The following is a description of a gene set: Human Gene Set: DARWICHE_PAPILLOMA_PROGRESSION_RISK Genes that classify progression risk of benign papilloma samples: low vs high risk. studied in species Mus musculus from publication Darwiche N, Ryscavage A, Perez-Lorenzo R, Wright L, Bae DS, Hennings H, Yuspa SH, Glick AB (PMID 17525749) Chemical induction of squamous tumors in the mouse skin induces multiple benign papillomas: high-frequency terminally benign low-risk papillomas and low-frequency high-risk papillomas, the putative precursor lesions to squamous cell carcinoma (SCC). We have compared the gene expression profile of twenty different early low- and high-risk papillomas with normal skin and SCC. Unsupervised clustering of 514 differentially expressed genes (P<0.001) showed that 9/10 high-risk papillomas clustered with SCC, while 1/10 clustered with low-risk papillomas, and this correlated with keratin markers of tumor progression. Prediction analysis for microarrays (PAM) identified genes that distinguished the two papilloma classes, and a majority of these had a similar expression pattern in both high-risk papillomas and SCC. Additional classifier algorithms generated a gene list that correctly classified unknown benign tumors as low- or high-risk concordant with promotion protocol and keratin profiling. Reduced expression of immune function genes characterized the high-risk papillomas and SCC. Immunohistochemistry confirmed reduced T-cell number in high-risk papillomas, suggesting that reduced adaptive immunity defines papillomas that progress to SCC. These results demonstrate that murine premalignant lesions can be segregated into subgroups by gene expression patterns that correlate with risk for malignant conversion, and suggest a paradigm for generating diagnostic biomarkers for human premalignant lesions with unknown individual risk for malignant conversion., and this is the list of marker genes: CXCL16, NEK4, GGT7, ABHD14B, LIM2, PRKX, EGLN3, TEX26, RINL, GSTM5, NUDT12, PTX4 (pentraxin 4), MORN5, SGTA, ZNF787, LAG3, R3HCC1L, MXI1, CALCOCO1, C16orf96, XPC, ACKR3, C4orf54, SMIM33, KIF6, MCM4, SERPINH1, STOM, SLC38A10, PSORS1C2, GJB2, LGALS2, XDH, RELN, PRRT1, CD2AP, CYP3A5, TRAF2, HAND1, PLEKHM2, SIGLEC5, TMOD1, ZSCAN2, IGKV1-27, CLYBL, TRBV11-3, NR6A1, TIA1, MFAP3L, HGD, IQCF1 (IQ motif containing F1), TTN, RAMP2, RGS14, CD2, CRKL, GSDMC, GPR37, DYRK1A, CATSPER3, TRPC6, COL20A1, MAN2A2, KPNB1, DOCK4, UCK2, TCHHL1 (NCBI Gene Id 126637), TNFRSF12A, IGLV2-18, MUC2, ATG2A, AFF3, FMO5, CHCHD5, SOX4, ACTL6B, KRTAP6-1, THEM5